Given this list of marker genes IL18, IKZF1, CASKIN1, SLC10A4, TMEM267, PRXL2B, CAPRIN2, DRAM1, PHF19 (PHD finger protein 19), HLA-B, CYP26B1, IQCK, RIIAD1, PYROXD2, ARPIN, UBE2N, PCYT1B, GBP6, RPA3, CD79A, MGAT5 (alpha-1,6-mannosylglycoprotein 6-beta-N-acetylglucosaminyltransferase), METTL25B, S1PR2, RIMKLB, PARD6B, CD40, ACSS2, DUSP18, CCNC, RPS15A, HNRNPA2B1, MIER2, FBXL12, DRC12, NOCT, COL6A1, VANGL1, PPP6C, CYSRT1 (NCBI Gene Id 653325), TRIP10, FMO1, SCHIP1, TSHR, RBP7, TMEM69, IFNG, KCNJ6, INSL5, KCNC2, SNORD123, ARHGEF10, ZCCHC8, TGFB2, TNFSF14, MAST4, COLGALT2, SDC4 (syndecan 4), GCSH, FAM43A, ACP3, SNCB, IFT25, PRICKLE2, HMGB1, HLA-G, HCRTR2, SLC41A1, IL17RE, CACNA1C, CES5A, CHST10, USP18, GGT7, NUP160, NIPA1, USF1, GRK3, CTF1, NLRC5, PCDH9, P4HA2, FLJ13224, GP5, MDM1, CGA, KCTD7, CAPZA2, OR7C1, BMF, USPL1, SUB1, BTBD3, ARSJ, SPATA31F1, C6orf58, AXDND1, RBM45, NEK11, GRM3, KRTAP4-11, ZNF280D, TSPO, MZB1, HSD11B1 (NCBI Gene Id 3290), PCDH15, C10orf90 (chromosome 10 open reading frame 90), SOX21, REG1B (NCBI Gene Id 5968), IRF9, LOXL1, GSX1, KRT81, IFI27L2, TMEM170A, LPAR6, RMC1, RCBTB2, FUBP1, YES1, TMEM128, PTCHD3, ADCY5, CYFIP1, AGAP2, CACNA1E, SLC30A3, H3-5, ACYP1, TMEM88, TASOR2, RNF213, MAN1A2, HYKK, CSRP1, SHROOM4, CD2, CTSE, EPHB3, PTTG1, DYNLT5, IVNS1ABP, PLAC8, CA10, SP3, NMNAT1, CPSF6, ARGLU1, RPTN (NCBI Gene Id 126638), FRMPD3, SPMAP2L, SPCS2, KYNU, TKFC, SPINT2, GDA, DDX3X, SAMD12, NECTIN3, RLN1, MAN2A1, TCEAL8, GRM5, RNF208, STAC2, CTSV, GALNTL5, PKN1, UQCRQ, SNX15, VPS13C, SYNGR2, TMPRSS11F, PPP2CA, PRELID3A, RSPH4A, SOX4, MREG, ZBED6, CCR6, CMC2, CA13, DYNLT1, NCKAP5, CPM, IFI27, HPX, TMEM181, STX1A, UGT2B10, SLC35B4, RASGRP4, CYB561A3, TRIQK, FRY, EMP2, ANXA5 (annexin A5), IFI30, NEU2, SMOC2, ITGB3BP, here is a description of the gene set: Genes up-regulated in monocytes (12h) versus macrophages (12h) treated with IL4. Human CD14 positive monocytes were purified from healthy volunteers’ blood and cultured in vitro for 4, 12, 24, 72 hours. While culturing, macrophages were activated alternatively with interleukin-4 (IL-4 100 ng/ml) or classically with interferon-gamma (IFNg 100 ng/ml)+tumor necrosis factor (TNF 50 ng/ml) or left without activation. Simultaneously, macrophages were also treated with vehicle (DMSO:ethanol) or 1mM synthetic PPARg agonist, Rosiglitazone. We used Affymetrix microarrays (U133Plus 2.0) to analyze activation and PPARg-induced gene expression changes. Human Gene Set: GSE16385_MONOCYTE_VS_12H_IL4_TREATED_MACROPHAGE_UP species: Homo sapiens from publication Szanto A, Balint BL, Nagy ZS, Barta E, Dezso B, Pap A, Szeles L, Poliska S, Oros M, Evans RM, Barak Y, Schwabe J, Nagy L (PMID 21093321)